Given this list of marker genes WSB1, MEG3 (maternally expressed 3), GOLGB1, VMP1, NKTR, MALAT1, ARGLU1, HNRNPU, OGT, KCNQ1OT1, ATXN1, LAMB1, DDX17, TEAD1, SPEN, COL11A1, TRIO, PNISR, MACF1, XIST, LENG8, LUC7L3, RBM5, HNRNPH1, MXRA5, ARHGEF12, RUNX1, STAT2, XAF1, LPP, FAT1, ANKRD36C, DYNC1H1, RNF213, MAP4K4, ZNF638 (zinc finger protein 638), ASH1L, NEAT1, SYNE1, SULF1, BPTF, ENAH, PEAK1, NFAT5, RIF1, ZKSCAN1, COL12A1, CCNL2, DST, PHLDB1, here is a description of the gene set: In this study, an extensive analysis was conducted to define meta-programs (MPs) capturing intra-tumor heterogeneity across a spectrum of tumor types. The approach utilized non-negative matrix factorization (NMF) to analyze each cell type separately within individual tumor samples. This involved the analysis of malignant cells, macrophages, fibroblasts, endothelial cells, epithelial cells, T-cells, and B-cells. NMF was executed with varying parameter values (K=4, 5, 6, 7, 8, 9), thereby generating 39 programs for each cell type per sample. Each NMF program was summarized by the top genes based on NMF coefficients.\nRobust MPs were then delineated for each cell type using a set of stringent criteria, including recurrence within the same tumor, similarity to programs in other tumors, and non-redundancy within a tumor. Subsequently, these robust NMF programs were clustered (per cell type) based on Jaccard similarity, leading to the identification of MPs associated with each cell type.\nTo enhance the quality of the MPs, a refinement steps were undertaken, involving the removal of MPs suspected of reflecting low-quality data (with an overrepresentation of ribosomal proteins or mitochondrial-encoded genes), single-study inclusion, or similarity to miss-annotated cell types. from publication Gavish A, Tyler M, Greenwald AC, Hoefflin R, Simkin D, Tschernichovsky R, Galili Darnell N, Somech E, Barbolin C, Antman T, Kovarsky D, Barrett T, Gonzalez Castro LN, Halder D, Chanoch-Myers R, Laffy J, Mints M, Wider A, Tal R, Spitzer A, Hara T, Raitses-Gurevich M, Stossel C, Golan T, Tirosh A, Suvà ML, Puram SV, Tirosh I (PMID 37258682) species: Homo sapiens Genes upregulated in subsets of cells of a given type within various tumors Human Gene Set: GAVISH_3CA_METAPROGRAM_FIBROBLASTS_CAF_4